The following is a description of a gene set: Human Gene Set: GOMF_AMINO_ACID_PROTON_SYMPORTER_ACTIVITY Enables the transfer of a solute or solutes from one side of a membrane to the other according to the reaction: amino acid(out) + H+(out) = amino acid(in) + H+(in). studied in species Homo sapiens, and this is the list of marker genes: SLC36A2, SLC36A3, SLC25A18, SLC32A1, SLC25A22, SLC36A1